The following is a description of a gene set: studied in species Mus musculus Mouse Gene Set: MIR_6387 from publication Chen Y, Wang X (PMID 31504780) Genes predicted to be targets of miRBase v22 microRNA mmu_miR_6387 in miRDB v6.0 with MirTarget v4 prediction scores > 80 (high confidence targets)., and this is the list of marker genes: Rbm27, Unc119b, Ipo8, Gpr3, Frs2, Aak1, Sigmar1, Dlg2, Nfatc3, P2ry1 (purinergic receptor P2Y, G-protein coupled 1), Tpm3, Gpd2, Tmem125, Arf4, Coro1c, Map4k2, Atp2b4, Prorsd1, Mprip (myosin phosphatase Rho interacting protein), Fbxo33, Pmp22, Bbs1, Defb29, Slc39a10, Nfat5, Suz12 (NCBI Gene Id 74815), Mon2, Nav1, Nedd9, Man1a, Ywhaz, Bmt2, Osbp, Sema6d, Pcdh15, Zfp202, Sapcd2, Elf1, Fndc3a, Necab1, Ddx3x, Sec61a1, Nlk, Tmem59, Glcci1, Foxp1, Twf1, Tmem235, Pianp, Zfp583, Xpo6, Calm1, Calm2, Prkacb, Ccnd2, Dlg1, N6amt1, Mmd, Ss18 (SS18, subunit of BAF chromatin remodeling complex), Setbp1, Kif2a, Unc13b, Adpgk, Sgip1, Tmem178, Cttnbp2nl, Cdh8, Serp1, Max, Uts2r, Kmt2e, Ppia, Ptprg, Hnrnpu, Neto1, Kat6a, Entpd7, Ccz1, Camsap2, Tex2, Palld, Gja1, Lrrc3, Frem1, Tnks2, Cstf2, Ywhaq, Gclc, Ncoa1, Tab3, Gak, Zfp36l2, Defb41, Luc7l, Onecut2, Dmbx1, Stmn2, Xkr8, Pip4p1, Pik3c2a, Lrch1, Cavin2, Crebl2, Ccdc6 (coiled-coil domain containing 6), Galnt6, Mecp2, Ppp2r5a, Gpr158, Borcs7, Lasp1, Arcn1, Cnr1, Hinfp, Tbx3, Ccnd1, Atp11c (NCBI Gene Id 54668), Dnai4, Klhl5, Aspa, Map1a, Nmt2, Stk39, Syt1, Gnb1, Msx2, Sri, Kpnb1, Mfsd14a, Mctp1, Prx, Dach1, Ets1, Hspe1, Masp2, Klf4, Myocd, Ush1g, Ndel1, Glce, Stag2, Actb, Pcdh17, Unkl, Tagln2, Pgam1, Nsf, Mtss1, Eeig1, Thrb, Dolpp1, Slc25a1, Rnf150, Yes1, Phc1, Ankrd23, Crim1, Cap1, Kras, Mtx1, Med26, Gnpda2